The following is a description of a gene set: from publication Chen Y, Wang X (PMID 31504780) studied in species Homo sapiens Genes predicted to be targets of miRBase v22 microRNA hsa-miR-6503-3p in miRDB v6.0 with MirTarget v4 prediction scores > 80 (high confidence targets). Human Gene Set: MIR6503_3P, and this is the list of marker genes: KIF2A, TRIM62, HNRNPLL, GNG2, ZFAND3, PABPC1, NLN, RAB2A, CFAP65, SYT13 (synaptotagmin 13), SERP1, SLC6A4, NUDT5, TRPV4, ITPR1, MPP3, OR6A2, SERINC1, PHC3, AK7, RPL36A, HTR1F, PABPC3, ZZZ3, DICER1, RB1, VPS53, CDH26, ISL1, LRRC57, LARP1